Given this list of marker genes VAV3, APPL1 (NCBI Gene Id 26060), LYN, PTK2, YES1, VAV2, SRC, PLPP4, ABL1, FYN, SYK, HCK, PLA2G6, LIMK1, FCER2, MYO1G, PRKCD, PAK1, NOS2, FGR, PRKCE, VAV1, APPL2, IFNG, PLD2, here is a description of the gene set: An immune response-regulating cell surface receptor signaling pathway that contributes to the endocytic engulfment of external particulate material by phagocytes. Human Gene Set: GOBP_IMMUNE_RESPONSE_REGULATING_CELL_SURFACE_RECEPTOR_SIGNALING_PATHWAY_INVOLVED_IN_PHAGOCYTOSIS studied in species Homo sapiens